Given this list of marker genes GNAS, PRKACB, PRKAR2B, ADCY3, ADCY1, PRKACG, ADCY5, PRKAR1B, PRKAR1A, PRKACA, ADCY6, ADCY2, ADCY9, ADCY4, ADCY8, ADCY7, PRKAR2A, here is a description of the gene set: part of: Glucagon signaling in metabolic regulation Reactome Pathway: PKA activation in glucagon signalling Adenylate cyclase catalyses the synthesis of cyclic AMP (cAMP) from ATP. In the absence of cAMP, protein kinase A (PKA) exists as inactive tetramers of two catalytic subunits and two regulatory subunits. cAMP binding to PKA tetramers causes them to dissociate and release their catalytic subunits as active monomers. Four isoforms of the regulatory subunit are known, that differ in their tissue specificity and functional characteristics, but the specific isoform activated in response to glucagon signaling has not yet been identified. species: Homo sapiens